The following is a description of a gene set: studied in species Homo sapiens Enables the transport of a solute across a membrane via a narrow pore channel that may be gated or ungated. Human Gene Set: GOMF_NARROW_PORE_CHANNEL_ACTIVITY, and this is the list of marker genes: PANX1, KCNK4, KCNK3 (potassium two pore domain channel subfamily K member 3), KCNK16, TMEM175, KCNK10, KCNK13, KCNK1, KCNK6, KCNK15, KCNK5, KCNK7, KCNK2, RHAG, KCNK12, KCNK17, NALCN, KCNK18, KCNK9